The following is a description of a gene set: species: Mus musculus Mouse Gene Set: REACTOME_INTERLEUKIN_27_SIGNALING Interleukin-27 signaling, and this is the list of marker genes: Jak2, Il27, Ebi3, Stat3, Canx, Il6st, Crlf1, Tyk2, Il27ra